The following is a description of a gene set: Lipophagy species: Homo sapiens Human Gene Set: REACTOME_LIPOPHAGY, and this is the list of marker genes: PRKAB1, PLIN3 (NCBI Gene Id 10226), HSPA8 (heat shock protein family A (Hsp70) member 8), PRKAG2, PRKAG1, PRKAG3, PRKAB2, PRKAA2, PLIN2